Given this list of marker genes AOC1 (amine oxidase copper containing 1), LOXL1, LOXL3, LOXL4, LOXL2, LOX, here is a description of the gene set: Catalysis of the reaction: a diamine + H2O + O2 = a monoamine + NH4+ + H2O2. studied in species Homo sapiens Human Gene Set: GOMF_DIAMINE_OXIDASE_ACTIVITY